Given this list of marker genes GNPTAB, B3GALT6, DSE, CHST14, RMRP (NCBI Gene Id 6023), NFIX, COMP, here is a description of the gene set: species: Homo sapiens Human Gene Set: HP_ATLANTOAXIAL_DISLOCATION Partial dislocation of the atlantoaxial joint. Atlantoaxial dislocation